Given this list of marker genes 4930550C14Rik, Mfn1, Pink1, Pparg, Mapt, Carlr, Prkn, Ppargc1a, Mfn2, here is a description of the gene set: Any process that decreases the rate, frequency or extent of mitochondrial fission. Mitochondrial fission is the division of a mitochondrion within a cell to form two or more separate mitochondrial compartments. Mouse Gene Set: GOBP_NEGATIVE_REGULATION_OF_MITOCHONDRIAL_FISSION studied in species Mus musculus